The following is a description of a gene set: Human Gene Set: MIR8054 Genes predicted to be targets of miRBase v22 microRNA hsa-miR-8054 in miRDB v6.0 with MirTarget v4 prediction scores > 80 (high confidence targets). species: Homo sapiens from publication Chen Y, Wang X (PMID 31504780), and this is the list of marker genes: STEAP2, GSPT2, DDX5, TRIP11, SUMO1, EIF5A2, DMXL2, PTPRM, NEDD4L, SRSF6, PRR23A (NCBI Gene Id 731675), GDA, ABHD3, ATXN1L, RPGR, SLC9A6, PSPH, TLX3, VEZF1, PDK1, KRAS, BPNT2, ERICH2, NPAP1, SORBS2, NCAPG2, FBXO43, LRP2, CEP120, TM9SF3, YWHAZ (tyrosine 3-monooxygenase/tryptophan 5-monooxygenase activation protein zeta), CDK19, MAP4K5, ANKRD11, PRELID1, MEX3D, TBCA, SEMA6D, MLH3, ZNF600, GUCY1A2, CCSER2, IGF2BP3, DNAJB4, NFE2L2, ZNF611, CSNK1D, TP53TG3C, MAP3K7CL, LSM8, CNTN1, REPS2, TCEAL8, TOP2A, CUL4A, MSN, PROSER1, WWP2, MARCHF6, TAF12, RAB11A, HECA, SERPINB3, ANKRD22, NECTIN1, GPATCH2L, SCML2, IGFL1, GOLT1B, TWF1 (twinfilin actin binding protein 1), ANKDD1B, SAMD8, BCLAF3, CARF, CD47, MTF1, TTC17, CCNL1, AFG3L2, PDS5B, RASGRP1, CACNA2D3, SH3RF3, MED6, NR1I2, SLC24A3, ANXA2, SLC35A1 (solute carrier family 35 member A1), RNF138, MEF2C (NCBI Gene Id 4208), CD164, SATB2, SERTAD2, CBLB, WNT5A, CCNY, PDZRN3, CTNND1, GLIPR2, PTAR1, C5orf15, MEX3B, CPNE4, SERINC5 (NCBI Gene Id 256987), PTMA, CNN3, MFSD14A, ZNF800, PDZD8, EIF2AK3, OTUD4, WWP1, VPS4B, BRD1, GOPC, ZNF789, ELAVL4, RNF148, TRIM43B, KLHL28, TANC1, SPTLC2, LCORL, RAB6B, LIN7C, CNTN5, SH2D1A, ARID4B, IVNS1ABP, ZEB2, HTR2C, BICD1, KMT5B, FNDC3B, BBX, SAR1B, KLHL3, PPP3CB, RSRC2, HYOU1, PLEKHG1, FAM120A, TRIM43, UGT2B17, FIGN, POU2F1, MMUT, GOLPH3, MTCP1, YTHDF1, FAM13C, PTBP3, KLF10, ST8SIA1, ARHGEF38, NFAT5, ROBO1, ACAT2, WDR11 (WD repeat domain 11), ANGPTL5, SMOC2 (NCBI Gene Id 64094), FMR1, LGI1, ENC1, ITGAV, GJB7, THSD7A, TAB3, LY75, GPATCH11, ADAM22, ZNF26, PPP3CA, DMRT2, AP1G1, FEM1C, UCK2, CYP1B1, A1CF, UBE2B, WDR77, YWHAQ, HDAC4, GMNC, CEP350, MAP3K2, ZNF711, DSCC1, KITLG, DAP, PPHLN1, NUP153, AAK1, SPDL1, SPON1, PTPN12, MIER3, ATOSA, TMEM229A, ZNF493, WNK3, TBC1D3B, SKIL, MYCN, PAXIP1, MEF2A (NCBI Gene Id 4205), GULP1, SPCS2, PNN, RBM18, CISD2, LMBR1, DSP, OCIAD2 (OCIA domain containing 2), HYCC1, IL23A, TMEM100, BEND4, TGFBR1, ZDHHC17, GSTM2, PDZRN4, NEGR1, RUFY3, NAPB, TADA1, ZNF680, ORC3, ITGA9, IKZF5, SCARB2, NCKAP1, CPNE2, FMNL2, CD55, SLC5A3, KLF8, MAP9, RAP1A, EFNA5, AR (NCBI Gene Id 367), ADAMTS6, CDK6, PPP6C, SOS2, REEP3, FUBP1, BNIP3, PKN2, RRM2B, KAT6A, ZNF281, ZBTB44, KLHL13, GPM6A, DDIAS, ABCC4, C1D, OPRK1, FKBP7, POGLUT2, P2RY10 (NCBI Gene Id 27334), NOTCH1 (NCBI Gene Id 54781), PDE1A, RUNX2 (NCBI Gene Id 860), RAB9B, P4HB, CXADR, LRP12, EPC1 (enhancer of polycomb homolog 1), TMEM156, MYBL1, SNTB1, KCTD18, ZIC1, PREX2, MID2, HS2ST1, SINHCAF, ATRX, TCP1, APPBP2, RNF111 (ring finger protein 111), FAM168B, PI4K2B, BCL10, STXBP5, LPCAT2, C5orf24, ZNF486, TENT4B, RHOQ, ADAMTS1, UBE2A, SMG1, VPS26C, KCNK2, CD109, MCOLN3, MGAT4A, CELF5, NCOR1, FNIP2, TNC, GRIP1, ZBTB41, SS18